Given this list of marker genes SULT1A2, SULT1A1, SULT1C2, SULT1A4, SULT1A3, SULT1C4, SULT1B1, SULT1C3, SULT1E1, here is a description of the gene set: species: Homo sapiens Catalysis of the reaction: 3'-phosphoadenosine 5'-phosphosulfate + a phenol = adenosine 3',5'-bisphosphate + an aryl sulfate. Human Gene Set: GOMF_ARYL_SULFOTRANSFERASE_ACTIVITY